The following is a description of a gene set: studied in species Mus musculus We report the application of single-molecule-based sequencing technology for high-throughput profiling of histone modifications in mammalian cells. By obtaining over four billion bases of sequence from chromatin immunoprecipitated DNA, we generated genome-wide chromatin-state maps of mouse embryonic stem cells, neural progenitor cells and embryonic fibroblasts. We find that lysine 4 and lysine 27 trimethylation effectively discriminates genes that are expressed, poised for expression, or stably repressed, and therefore reflect cell state and lineage potential. Lysine 36 trimethylation marks primary coding and non-coding transcripts, facilitating gene annotation. Trimethylation of lysine 9 and lysine 20 is detected at satellite, telomeric and active long-terminal repeats, and can spread into proximal unique sequences. Lysine 4 and lysine 9 trimethylation marks imprinting control regions. Finally, we show that chromatin state can be read in an allele-specific manner by using single nucleotide polymorphisms. This study provides a framework for the application of comprehensive chromatin profiling towards characterization of diverse mammalian cell populations. from publication Mikkelsen TS, Ku M, Jaffe DB, Issac B, Lieberman E, Giannoukos G, Alvarez P, Brockman W, Kim TK, Koche RP, Lee W, Mendenhall E, O'Donovan A, Presser A, Russ C, Xie X, Meissner A, Wernig M, Jaenisch R, Nusbaum C, Lander ES, Bernstein BE (PMID 17603471) Mouse Gene Set: MIKKELSEN_ES_LCP_WITH_H3K4ME3_AND_H3K27ME3 Genes with low-CpG-density promoters (LCP) bearing the bivalent histone H3 trimethylation mark at K4 and K27 (H3K4me3 and H3K27me3) in embryonic stem cells (ES)., and this is the list of marker genes: Gal3st4, Fut7, Slc16a8, Cdh7, Btbd17, Slc17a7, Stra6